Given this list of marker genes CELF1, HNRNPH3, NEXN, ARL5B, RIMBP2 (NCBI Gene Id 23504), GLRA2, ATP1B1, TMCC1, TAFA1, ZNF654, ANKRD28, PACC1, ARRDC3, CSNK1A1, CRK, SLC49A4 (NCBI Gene Id 84925), BAAT, ABRAXAS2, here is a description of the gene set: species: Homo sapiens Human Gene Set: CTACTAG_MIR325 Genes having at least one occurence of the motif CTACTAG in their 3' untranslated region. The motif represents putative target (that is, seed match) of human mature miRNA hsa-miR-325 (v7.1 miRBase).